Given this list of marker genes IDH2, GOT1 (glutamic-oxaloacetic transaminase 1), KYAT3, TAT, DLD, GOT2, OGDHL, DLST, GPT2, OGDH, COL6A1, L2HGDH, D2HGDH, IDH1, KGD4, AADAT, PHYH, ADHFE1, here is a description of the gene set: species: Homo sapiens Human Gene Set: GOBP_2_OXOGLUTARATE_METABOLIC_PROCESS The chemical reactions and pathways involving oxoglutarate, the dianion of 2-oxoglutaric acid. It is a key constituent of the TCA cycle and a key intermediate in amino-acid metabolism.